The following is a description of a gene set: Proteins secreted in co-culture of LKR-13 tumor cells (non-small cell lung cancer, NSCLC) and MLg stroma cells (fibroblasts). from publication Zhong L, Roybal J, Chaerkady R, Zhang W, Choi K, Alvarez CA, Tran H, Creighton CJ, Yan S, Strieter RM, Pandey A, Kurie JM (PMID 18757440) Human Gene Set: ZHONG_SECRETOME_OF_LUNG_CANCER_AND_FIBROBLAST Non-small cell lung cancer (NSCLC) cells with somatic mutations in K-ras recruit to the tumor a variety of cell types (hereafter collectively termed stromal cells) that can promote or inhibit tumorigenesis by mechanisms that have not been fully elucidated. Here, we postulated that stromal cells in the tumor microenvironment alter the tumor cell secretome, including those proteins required for tumor growth and dissemination, and we developed an in vitro model to test this hypothesis. Coculturing a murine K-ras mutant lung adenocarcinoma cell line (LKR-13) with a murine lung stromal cell (macrophage, endothelial cell, or fibroblast) enhanced stromal cell migration, induced endothelial tube formation, increased LKR-13 cell proliferation, and regulated the secretion of proteins involved in angiogenesis, inflammation, cell proliferation, and epithelial-to-mesenchymal transition. Among these proteins, CXCL1 has been reported to promote NSCLC development, whereas interleukin-18 (IL-18) has an undefined role. Genetic and pharmacologic strategies to inhibit CXCL1 and IL-18 revealed that stromal cell migration, LKR-13 cell proliferation, and LKR-13 cell tumorigenicity required one or both of these proteins. We conclude that stromal cells enhanced LKR-13 cell tumorigenicity partly through their effects on the secretome of LKR-13 cells. Strategies to inhibit tumor/stromal cell interactions may be useful as therapeutic approaches in NSCLC patients. species: Mus musculus, and this is the list of marker genes: LGALS4, PRDX6, NPC2, VCL, PHACTR4, PPIC, YWHAB (tyrosine 3-monooxygenase/tryptophan 5-monooxygenase activation protein beta), YWHAZ, CHAF1A, TNXB, MTAP, AKR1B1, GSTO1, TPI1, ATP6AP2, SDC4, EEF2, SPARC, APOH (apolipoprotein H), YWHAQ, PEBP1, LGALS3BP, UBA52, EEF1A2, APP, QSOX1, ANXA4, SERPINB6, ENO3, PKM, TIMP2, GSR, AGRN (agrin), VCAM1, LDHA, TF, PGK1, GSTP1, P4HB, GSTM5, CTSB, VCP, PRSS2, HSP90AB1 (NCBI Gene Id 3326), PSMA5, CST3, PNP, NPM1, HSP90B1, ENO1, RACK1, WDR1, SLK, ARHGDIA, AHSG, ALDOA, CANT1, GLOD4, TINAGL1, HMGB1, PSMA7, PSMA3, GLO1, MSLN, ACTN4, RPL10A, MDH2, PSMB5, CTSD, ITIH2, CDH17, CTSZ, LMNA, CX3CL1, C2, PSMB6, SET, CYTIP, ACTN1, NUCB1, PSMB2, PSMA4, RAN, KXD1, LXN, KRT73, YWHAH, PARK7, CTRB1, RHOA, CD9, CAPG, BGN, ACTB, PSMB1, SERPINC1, PRDX1, TPT1, ME1, PSMA1, CFB, IMPA1, PSMB4, HGFAC, CD81, FUCA1 (NCBI Gene Id 2517), CALR, COL18A1, RPL18A, SEMA3C, CLSTN1, HPRT1, ACTA2, LAP3, ECM1, GOT1, KCTD7, FAM3C, COL1A1, GPI (glucose-6-phosphate isomerase), CP, CDH1, YWHAE (tyrosine 3-monooxygenase/tryptophan 5-monooxygenase activation protein epsilon), ENPP2, PSMB3, PGAM2, DNPEP, SPP1, FN1, MSN, CLU